The following is a description of a gene set: Reactome Pathway: Molecules associated with elastic fibres species: Homo sapiens part of: Elastic fibre formation Proteins found associated with microfibrils include vitronectin, latent transforming growth factor beta-binding proteins, emilin, members of the microfibrillar-associated proteins (MFAPs, Gibson et al.1996), and fibulins. The significance of these interactions is not well understood but may help mediate elastin-fibrillin interactions during elastic fibre assembly.<br><br>Proteoglycans such as versican, biglycan, and decorin can interact with the microfibrils. They confer specific properties including hydration, impact absorption, molecular sieving, regulation of cellular activities, mediation of growth factor association, and release and transport within the extracellular matrix. In addition, glycosaminoglycans have been shown to interact with tropoelastin through its lysine side chains regulating tropoelastin assembly., and this is the list of marker genes: TGFB2, LTBP4, ITGAV, BMP4, BMP2, ITGB1, FBLN1, MFAP5, EFEMP1, VTN, LTBP3, EFEMP2, MFAP2 (microfibril associated protein 2), ITGB8, FBN3, ITGB5, BMP10, LTBP2, ITGB3, FN1, FBN2, TGFB3, ITGA8, MFAP4, EMILIN3, EMILIN1, FBLN5, ITGB6, MFAP3, FBN1, GDF5, FBLN2, EMILIN2, ELN, BMP7, LTBP1, TGFB1